The following is a description of a gene set: Genes predicted to be targets of miRBase v22 microRNA mmu_miR_378b in miRDB v6.0 with MirTarget v4 prediction scores > 80 (high confidence targets). species: Mus musculus Mouse Gene Set: MIR_378B from publication Chen Y, Wang X (PMID 31504780), and this is the list of marker genes: Pramel3c, Epha3, Cnot7, Scn5a, Sec14l1, Npr3, En2, Srrm4, Morn2, Pheta2, Crebrf, Rbm44 (NCBI Gene Id 633065), Mrps5, Phf21a, Prpf40a, Hecw1, Dnajc19, Chd9, Hnrnpa0, Tex38, Edn1, Prr23a1, Ptgds, Igf2bp3, Ywhaq, Gnat1, Six3, Bltp3b, Ppp1r3a, Dach1, Fst, Zfp1008, Ralgapb, Rpp40, Palmd, Prkar2a, Rap1b, Hacd1, Mob3c, Prcd, Pramel3b, Igf1, Lrrc40, Kcnj3, Ufm1, Wrn, Lipo2, Crhbp, Seh1l, Gna13, Rapgef4